Given this list of marker genes FOXI1, HAAO, PI4KB, KCNJ10, SLC26A4, EYA1, SIX1, COL4A6, ORC1 (origin recognition complex subunit 1), here is a description of the gene set: species: Homo sapiens Incomplete formation of the cochlear partition. The scala vestibuli and scala tympani separated by the cochlear partition, except in the apical turn where the two scalae are in continuity via the helicotrema. Incomplete partition of the cochlea Human Gene Set: HP_INCOMPLETE_PARTITION_OF_THE_COCHLEA